Given this list of marker genes SCN1A, CUX2, MTOR (mechanistic target of rapamycin kinase), MAPK10, AKT3, PIK3CA, CHD2, HID1, CACNA1A, GABRB3, AFG2A, GNB1, DNM1, here is a description of the gene set: studied in species Homo sapiens EEG with focal sharp slow waves EEG with focal sharp transient waves of a duration between 80 and 200 msec followed by a slow wave. Human Gene Set: HP_EEG_WITH_FOCAL_SHARP_SLOW_WAVES